The following is a description of a gene set: The aim of this dataset was to study in detail the transcription kinetics initiated by cytokine IL-4 in early differentiation of Th2 cells. Human Gene Set: GSE17974_IL4_AND_ANTI_IL12_VS_UNTREATED_6H_ACT_CD4_TCELL_UP from publication Elo LL, Järvenpää H, Tuomela S, Raghav S, Ahlfors H, Laurila K, Gupta B, Lund RJ, Tahvanainen J, Hawkins RD, Oresic M, Lähdesmäki H, Rasool O, Rao KV, Aittokallio T, Lahesmaa R (PMID 20620947) studied in species Homo sapiens Genes up-regulated in comparison of CD4 T cells treated with IL4 and anti-IL12 at 6 h versus the untreated cells at 6 h., and this is the list of marker genes: ELAPOR2, ZNF443, PSMG3-AS1, IL1RN, SLC25A31, GAB3, TMEM253, DIPK1A, LINC01091, CSPG5, CFAP92, EPAS1, KIF3C, DLC1, CKB, ARGLU1-DT, ZBTB22 (NCBI Gene Id 9278), PARP3, LTBP1, GABRB3, RAB27B, SLCO3A1, HNRNPUL2, KPNA6, PLA2G2A, ODAD3, IL10RA, TM4SF1, CASQ1, MYL11, RASGRP3, CPEB1, TMEM158, SLC25A42, WNT5B, ZNF155, RTN2 (NCBI Gene Id 6253), PCED1B, PDGFC, CASKIN2, SHOC1, CAMK2D, PATJ, ASTN2, TLR3 (toll like receptor 3), CD8B, DNAH8, JRK, VLDLR, PAPPA (NCBI Gene Id 5069), CCDC9B, INSM2, TEX9, HESX1, RRAGD, RBPMS, MAOA, ANGPTL1, PTPN7, MFSD6, TTC22, GATA3, CGA (NCBI Gene Id 1081), PGPEP1, RNF125, SST, ST6GALNAC1, ZFHX4, FBXL18, C3orf18, TTLL13, ABCA6 (ATP binding cassette subfamily A member 6), DLG3, CHN2, CCDC102A (coiled-coil domain containing 102A), SYNE1, GPR183 (G protein-coupled receptor 183), IRX5, TTC9C, PSKH1, CAP2, UGT2B17, GABRB1, DACH1, SPINT2, GABRA4, ALOX5, NPY5R, DUSP6, PATL2, SCN3A, PCED1B-AS1, PTPN14, CDK2, FAM236A, GAB2, ENDOU (NCBI Gene Id 8909), PLCXD3, UBL3, VSIG10L, ZNF471, CLEC12A, ABHD8, MGAT4D, PLPP1, OR1F1, SLC6A1, HHIP-AS1, GPR3, MAP3K14-AS1, PLXDC1, IGFBP2, SPPL2C, PALD1, FCER2, LINC01550, IFNL1, S100A11 (NCBI Gene Id 6282), RNF128 (ring finger protein 128), SHLD1, DDB2, FBXL17, CDC45, EN1, GNA14, IGSF11, SLC28A1, PPARG, CATSPER3, SNTB1, NLRP5, ARHGAP18, LINC01281, STAT4 (NCBI Gene Id 6775), TAS2R13, KLK8, LHCGR (NCBI Gene Id 3973), RAD51B, HPCAL1, PPP1R17, WWC3, TPRG1, ZNF663P, ABCC6P1, EREG, ZNF462, TRABD2A, CD8A, SOCS1, AGAP12P, LINC01116, GS1-600G8.3, EEIG2, ASCL1, PLK4, LRRC66, ZBTB14, GNAI1, RAB30, CLDN5, SEPTIN10, PCDHB16, TTC28-AS1, SCGN, PTPRD, SERPINB12, NRP2, TSHZ1, HSBP1L1, ENKUR, RHOQ, MSI2, CYSRT1, DSEL (dermatan sulfate epimerase like), PJVK, SLC6A16, GCOM1 (GCOM1, MYZAP-POLR2M combined locus), INS, SLC26A4, MACC1, PECAM1, TDH-AS1, ANKRD36BP2, KLHL29, SCIN, VN1R2 (vomeronasal 1 receptor 2), PDE9A, RBMS2, MSR1, ZCCHC12